Given this list of marker genes Srsf3, Arl13b, Ftcd, Ttc22, Fam219b, Pramel3b, Ankrd33b, Baz2b, Mbnl3, Prkdc, Trappc3, Ptdss1, Fzd3, Tectb, Pramel3e, Itga9, Adcy1, Atg5, Dag1, Gla, Ufc1, Myf5, Fut1, Dnajb5, Gad2, Gas7, Gga2, Abi1, 2310033P09Rik, Fbxo41, Kcnj13 (potassium inwardly-rectifying channel, subfamily J, member 13), Srsf1, Capn2, Nanos1, Ntrk2, Mtcl2, Fam131a (family with sequence similarity 131, member A), Mtfr1, Frmpd4, Trappc9, Slc52a3, Rhbdl3 (NCBI Gene Id 246104), Slc24a1, Hikeshi, Orai2 (ORAI calcium release-activated calcium modulator 2), Vezf1, Ubqln1, Fhip1b, Snrnp200, Tmem26, Pramel3a, Mmaa, Mab21l1, Galnt14, Src, Epha5, Pramel3c, Sec14l3 (SEC14-like lipid binding 3), Fam227a, Atp6v0b, Marveld3, Psg28, L2hgdh, Fubp1, Rere (arginine glutamic acid dipeptide (RE) repeats), Camk4 (NCBI Gene Id 52876), Insig1, Spry4, Ppp1r9b, here is a description of the gene set: from publication Chen Y, Wang X (PMID 31504780) Genes predicted to be targets of miRBase v22 microRNA mmu_miR_7033_3p in miRDB v6.0 with MirTarget v4 prediction scores > 80 (high confidence targets). Mouse Gene Set: MIR_7033_3P species: Mus musculus